Given this list of marker genes VEGFA, SYDE1, MIR16-1, FBN2, CALR, ACVR1C, MIR15B, ITGB3, ACVR1B, APELA, GJA1, AGO2, TIMP1, YTHDF3, C1QBP, SMURF2, ARHGDIB, NODAL, here is a description of the gene set: species: Homo sapiens Human Gene Set: GOBP_REGULATION_OF_TROPHOBLAST_CELL_MIGRATION Any process that modulates the frequency, rate or extent of trophoblast cell migration.